The following is a description of a gene set: species: Mus musculus Mouse Gene Set: GOCC_CAVEOLA A membrane raft that forms small pit, depression, or invagination that communicates with the outside of a cell and extends inward, indenting the cytoplasm and the cell membrane. Examples include flask-shaped invaginations of the plasma membrane in adipocytes associated with caveolin proteins, and minute pits or incuppings of the cell membrane formed during pinocytosis. Caveolae may be pinched off to form free vesicles within the cytoplasm., and this is the list of marker genes: Adtrp, Flot1, Cavin2, Gask1a, Cavin1, Tgfbr2 (NCBI Gene Id 76304), Hmox1, Cdh13, Slc2a3, Atp1a2, Tgfbr1 (NCBI Gene Id 674605), Coro1c, Src, Scn5a, Ctsb, Bmpr1a, Insr, Rangrf, Hk1, Cln3, Pacsin2, P2ry12, Atp1b1 (NCBI Gene Id 11931), Plpp2, Jak2, Plpp1, Kcnd2, Sele (NCBI Gene Id 20339), Plvap, Adcyap1r1, Entpd1, Ctnna1, Nos3, Adrb2, Efna5, Nos1ap, Mapk1, Cd36, Pld2, Adcy8, Cav3, Lrp6, Dlc1, Cavin4, Slc22a6, Aqp1, Spred1, Smo, Irs1, Trpc4, Cdh15, Cav2, Adra1a, Igf1r, Vdr, Erbb4 (erb-b2 receptor tyrosine kinase 4), Scarb1, Slc6a3, Sorbs1, Cav1, Akap6, Ehd2, Drd1, Bmpr2, Tfpi (tissue factor pathway inhibitor), Adra1b, Cdh1, Cacna1h, Mapk3, Myof, Emp2, Mlc1, Asah2, Kcnd3 (NCBI Gene Id 99868), Cacna1c, Atp1b3, Flot2, Neu3, Lrp8, Ptgs2, Tsc2, Nos1, Lrrk2, Slc27a1, Htr2a, Ptch1, Fxyd1, Bves, Ctnnd1, Hck, Ctnnb1, Cbl, Lipe, Cavin3, Atp1a1, Smpd2, Kif18a, Ldlr, Ptgis, Fasl, F2r, Gnaq, Kcnma1, Hdac6, Grk2, Slc2a1